The following is a description of a gene set: Catalysis of the reaction: NAD+ + H2O = ADP-D-ribose + nicotinamide + H+, in a two step reaction: first an ADP-ribosyl cyclase reaction to synthesise cyclic ADP-ribose, followed by a cyclic ADP-ribose hydrolase reaction to generate (linear) ADP-ribose. studied in species Homo sapiens Human Gene Set: GOMF_NADPLUS_NUCLEOSIDASE_ACTIVITY_CYCLIC_ADP_RIBOSE_GENERATING, and this is the list of marker genes: SARM1, IL1RL2, IL1RAPL1, TLR2, IL18R1, TLR10, BST1, TLR6 (toll like receptor 6), TLR4, IL1R1, IL1RAPL2, IL1RL1, CD38, IL1RAP, TLR1, IL18RAP